Given this list of marker genes FAU (NCBI Gene Id 55430), DAPK1, MS4A15, RPS19, RPS16, VIM (NCBI Gene Id 7431), GDF15, TIMP1, RPS13, RPL18, SFTPB, MGP, PIGR, CYP2B7P, HNMT, RPL36, TPT1, GPRC5A, ELAPOR1, HOPX, RPL31, SSR4, RPS7, RPL13, RPL27A, RPL23A, RPL32, RPS3, CXCL17, STEAP4, RPS24, AARD, FNIP2, RPL13A, RPS5, RPL10, RPL38, FLRT3, ZFP36L1, RPS15A, HSD17B13, RPL37A, FABP5, MET, ARHGDIB, RPL29, RPL15, CST3, FOLR1, RPL30, FCGR2A, CYB5A, RNASE1, TMSB4X, SOCS2 (NCBI Gene Id 8835), RPS15, FMO2, ERP27, SERP1, S100A13, RPS29, RPLP2 (NCBI Gene Id 6181), RPL35A (NCBI Gene Id 6165), RPL24, RPL26, HSD17B11, MRPS25, RPL5, RPS20, SEL1L3, CTSE, CMAHP, RPL35, RPL39, PTGS2, RPL37, RPL12, MGST1, CRACR2B, RPS11, RNF145, RPL11, RPL27, NIBAN1, RPL21, CRTAC1, RPS14, AGR3, AHR, CEACAM6, SOX4, SCGB3A2, FXYD5, RPL18A, RPS3A, CLIC6, RPS21, RPS12, RPS8, RPS27, RPL13AP5, RPL19, RPS23 (ribosomal protein S23), C16orf89, IL6ST, WSB1, FAM20A, RPS6 (NCBI Gene Id 92956), SFTA1P, NEDD4L, AREG, RPL34, SLPI, RPS28, here is a description of the gene set: species: Homo sapiens from publication Travaglini KJ, Nabhan AN, Penland L, Sinha R, Gillich A, Sit RV, Chang S, Conley SD, Mori Y, Seita J, Berry GJ, Shrager JB, Metzger RJ, Kuo CS, Neff N, Weissman IL, Quake SR, Krasnow MA (PMID 33208946) Human Gene Set: TRAVAGLINI_LUNG_CLUB_CELL